Given this list of marker genes TRAF3, MAX, LAMB1, COL4A1, PIK3CD, BIRC7, LAMB4, LAMC1, BIRC8 (baculoviral IAP repeat containing 8), DDB2, TRAF1, GADD45A, CDK4, RB1, CDKN1B, FN1, E2F2, CDKN1A, FHIT, RARB, CDKN2B, CDKN1C (cyclin dependent kinase inhibitor 1C), ZBTB17, TP53, CASP8, LAMA5, GADD45B, COL4A3, BCL2L1, PIK3CB, AKT3, LAMC2, PTEN, ITGA6, BIRC2, BAX (NCBI Gene Id 581), E2F1, LAMA4, NFKBIB, TRAF5, NOS2, RELA, CKS1B, COL4A4, NFKB1, CCNE1, AKT1, LAMA2, ITGAV, CHUK, CDK6, PTK2, LAMB3, PIK3CA, LAMA1, RXRB, TRAF4, PTGS2, BAK1, ITGA3, COL4A5, IKBKG, CYCS, ITGA2B, SKP1, ITGA2, TRAF6, CASP3, COL4A2, RXRG, LAMC3, APAF1, BCL2, MYC (MYC proto-oncogene, bHLH transcription factor), CKS2, BID, RXRA, CCND1, PIK3R1 (NCBI Gene Id 5295), LAMB2, AKT2, POLK, ITGB1, TRAF2, NFKBIA (NCBI Gene Id 4792), IKBKB, PIK3R2, COL4A6 (NCBI Gene Id 1288), CASP9, PIK3R3, BIRC3, CCNE2, LAMA3, E2F3, CDK2, GADD45G, here is a description of the gene set: studied in species Homo sapiens Human Gene Set: WP_SMALL_CELL_LUNG_CANCER Small cell lung cancer